Given this list of marker genes PHAF1, ZNF74, DCX, ACLY, SYT17, BID, TPRG1, ATP2B4, PCBP2, IL12A, THAP9, DPP10, CCDC179, FYCO1, SPHKAP (NCBI Gene Id 80309, SPHK1 interactor, AKAP domain containing), CCL8, MFNG (MFNG O-fucosylpeptide 3-beta-N-acetylglucosaminyltransferase), JMY, ARID2, SLC4A5, TFDP3, USP6NL, NRXN1, FOXN1, PLEKHG2, TSR1, RAB6D, EFR3A, MZF1 (NCBI Gene Id 90814), GNAL, E2F7, NCAPH2, UBR1, AMMECR1, KCNG4, GSG1L, SH3TC2, RORA, UBE2G1, ADAMTS3, SPPL3, TTC19, TIA1, TM2D3, SPON1, here is a description of the gene set: Genes predicted to be targets of miRBase v22 microRNA hsa-miR-3691-5p in miRDB v6.0 with MirTarget v4 prediction scores > 80 (high confidence targets). Human Gene Set: MIR3691_5P from publication Chen Y, Wang X (PMID 31504780) studied in species Homo sapiens